Given this list of marker genes CLEC4G, PFKM, ALDOA, SLC2A5, KHK, ALDOB, PFKL, here is a description of the gene set: studied in species Homo sapiens Human Gene Set: GOMF_FRUCTOSE_BINDING Binding to the D- or L-enantiomer of fructose, the ketohexose arabino-hex-2-ulose.